Given this list of marker genes Add1, Dact1, Lrp1, Gsk3b, Blk, Mark3, Bmp4, Bdnf, Anxa2, Vtn, Rfng, Fam220a, Hip1r, Sting1, Ide, B2m (beta-2 microglobulin), Ephb6, Agrn, Tmem132a, Ufl1, Usp33, Tiam1, Mapre1, Ripk2, Abl1, Plcl2, Lrrk2 (leucine-rich repeat kinase 2), Hipk2, Spon1, Usp9x, Epb41l5, Lfng, Nvl, Flot1, Cldn5, Nmd3, Cdk5, Mmp9, Ralb, Ip6k2, Rapgef2, Dtx3l, Prkn, Nphp3, Spta1 (spectrin alpha, erythrocytic 1), Add2, Abl2, Rpl11, Ep300, Ticam1, Pin1, Bmp2, Trim21, Krit1, Eif2ak3, Plxnd1, Pin1rt1, Plcl1 (phospholipase C-like 1), Ran (RAN, member RAS oncogene family), Cthrc1 (collagen triple helix repeat containing 1), Trib3, Bambi, Wnt5a, Arhgef7, Mfng, Tcf7l2, Tert, Epb41, Aktip, Spag8, Hfe, Mapre3, here is a description of the gene set: Mouse Gene Set: GOBP_POSITIVE_REGULATION_OF_PROTEIN_BINDING Any process that activates or increases the frequency, rate or extent of protein binding. studied in species Mus musculus